The following is a description of a gene set: An extremely narrow tubular channel located between adjacent cells. An instance of this is the secretory canaliculi occurring between adjacent parietal cells in the gastric mucosa of vertebrates. studied in species Homo sapiens Human Gene Set: GOCC_INTERCELLULAR_CANALICULUS, and this is the list of marker genes: ABCB4, MTDH, ABCC2, ABCB11, DPP4, STARD10